Given this list of marker genes Lrrc19, Lcor, Pik3r1, Eif5, Adamts17, Elapor2, Fdft1, Tardbp, Klhl24, Scn2b, Frrs1l, Ggnbp2, Spata6l (spermatogenesis associated 6 like), C2cd2l, Angel2, Gripap1 (NCBI Gene Id 54645), Kif7, Slitrk2, Inpp5a, Sp1, Plekhm3, Ptgr3, Adipor2, Shisa4, Myh1, Hif3a, Osbpl6, Slc13a5 (NCBI Gene Id 405903), Grhl2, Tada1, Actr10, Eif4g3, Mlycd, Cmip, Gm11545, Rmi1, Nalcn, Hs3st3b1, Gpank1, Ryk, Fjx1, Pomk, Them4, Pign, Usp44, Cip2a, Rreb1, Chd2, Gpd2, Pom121, Zfp788, Ppargc1a, Cpd, Rnf135, Ikzf2, Nat10, AW209491, Per1, Prkar1a, Cyld, Lratd1, Gpr88, Ssr3, Atp6v1h, Mbtd1, Map3k3, Nr1d2, Fads6, Amer1, Myb, Eml2, Coq3, Zfp235, Ust, Mylk, Cbll1, Cnga4, Kcnip1, Ephb2, Fut9, Trp53inp2, Kcnj15 (NCBI Gene Id 56497), Tfip11, Tspyl5, Lhx2, Fbxo21, Fbxw11, Capn8, Dusp13a, Hoxa9, Kitl, Rasef, Mgme1, Smim3, Bcat1, Gpr160, Mbd6, Prdm4, Ngrn, Ptx3, Sp5, Nectin2 (nectin cell adhesion molecule 2), Gdi1, Pdlim1, Manba, Tmem245, Prickle2, Elk1, Pappa, Igf1r, Gabrg2, Rnf34 (NCBI Gene Id 97276), Ndc1, here is a description of the gene set: Genes predicted to be targets of miRBase v22 microRNA mmu_miR_150_5p in miRDB v6.0 with MirTarget v4 prediction scores > 80 (high confidence targets). species: Mus musculus Mouse Gene Set: MIR_150_5P from publication Chen Y, Wang X (PMID 31504780)